Given this list of marker genes NELFA, ABCC5, MED13, LAMA5, ZW10, RAB27A, LYN, E2F3, FXR1, RASGRP1, RIF1, WWP1, NUP98, GPRC5B, SH3GL3, CD2AP, ATF2, PKIA, ADCY1, HSPA6, CYP2E1, RPP30 (ribonuclease P/MRP subunit p30), STX6, MAN2A2, ZNF536, GOSR2, IL15 (interleukin 15), DLG4, CDS1, PDIA4, SEC24A, ADGRL1 (NCBI Gene Id 79732), OCLNP1, SMG7, MITF, PPM1G, WNT11, MKLN1, TAP1, TMPO, CREM, HELZ, CDK2, LINC02802, ERBB3, RXYLT1, TP53BP2, UTP20, FGF9, PPP1R26, HSF2, HSD17B6 (NCBI Gene Id 8630), PTHLH, DCP2, ST7, GPC4, GAP43 (NCBI Gene Id 2596), NPY1R, SPTSSA, TRAF3IP1, CASP2, TOR1B, MYOZ3, NFKBIA, RAB33A, CCK, PPFIA1, PEG3, SLC25A4, TERF1, RSBN1 (NCBI Gene Id 54665), SS18L1, GAPVD1, FOXA2, ETV5, ZNF821, ENPP4, MINAR1, KCTD2, PPM1A, IL1RL1, TM4SF1, AMD1, CXADR, MTHFD2, PEX11A, NF1, KCNS3, SLC39A7, MORC3, ZFP37, HLTF, RUNDC3B, IL12A, CFDP1, ZFX, KHDC4, COIL, NCF2 (NCBI Gene Id 4688), TNFRSF17, SEC23IP, TLE3, PCGF3, SPAST, BAZ1A, PARP2, SLC1A4, SERPINB8, PAK3 (NCBI Gene Id 5063), THOC2, PRKAA2, M6PR, POLR2H, SORCS3, RETREG1, RFC5, SNX27, ERF, CDC5L, MRAS, CDC27 (NCBI Gene Id 996), ZWINT, CBLB, CREBZF, FAM168A, EYA4, SAR1A, CEP43, ZNF230, MPHOSPH9, SLC25A13, PPP1R2, NOP16, CYP19A1, CXCL8, RBBP4, MET, ZHX2, PTPN3, RO60, TOPBP1, E2F5, DDX18, NEK4, RXRB, OVGP1, RUBCN, LYSET, DHX30, SLC29A2, CASP6, PIK3R3, MAGOH, CD83, SEC23B, GSR, ZNF473, IL1RN, BHLHE40, STARD8, KATNA1, UBFD1, ATP8A1, UPF1, PPP3R1, AGO2 (NCBI Gene Id 286109), FNBP1L, CDO1, KIF3A, AKAP10, MCM3, CAPN7, TGDS, here is a description of the gene set: Genes up-regulated in primary fibroblast cell culture after infection with HCMV (AD169 strain) at 18 h time point that were not up-regulated at the previous time point, 16 h. Human Gene Set: BROWNE_HCMV_INFECTION_18HR_UP studied in species Homo sapiens from publication Browne EP, Wing B, Coleman D, Shenk T (PMID 11711622) The effect of human cytomegalovirus (HCMV) infection on cellular mRNA accumulation was analyzed by gene chip technology. During a 48-h time course after infection of human diploid fibroblasts, 1,425 cellular mRNAs were found to be up-regulated or down-regulated by threefold or greater in at least two consecutive time points. Several classes of genes were prominently affected, including interferon response genes, cell cycle regulators, apoptosis regulators, inflammatory pathway genes, and immune regulators. The number of mRNAs that were up-regulated or down-regulated were roughly equal over the complete time course. However, for the first 8 h after infection, the number of up-regulated mRNAs was significantly less than the number of down-regulated mRNAs. By analyzing the mRNA expression profile of cells infected in the presence of cycloheximide, it was found that a minimum of 25 mRNAs were modulated by HCMV in the absence of protein synthesis. These included mRNAs encoded by a small number of interferon-responsive genes, as well as beta interferon itself. Cellular mRNA levels in cytomegalovirus-infected cells were compared to the levels in cells infected with UV-inactivated virus. The inactivated virus caused the up-regulation of a much greater number of mRNAs, many of which encoded proteins with antiviral roles, such as interferon-responsive genes and proinflammatory cytokines. These data argue that one or more newly synthesized viral gene products block the induction of antiviral pathways that are triggered by HCMV binding and entry.